The following is a description of a gene set: studied in species Mus musculus Mouse Gene Set: GOBP_CYTOPLASMIC_ACTIN_BASED_CONTRACTION_INVOLVED_IN_CELL_MOTILITY The actin filament-based movement by which cytoplasmic actin filaments slide past one another resulting in a contraction that propels the cell from one place to another., and this is the list of marker genes: Vil1, Actc1, Shtn1, Myh9, Limch1